Given this list of marker genes POLR2B, NELFE, TAF8, SUPT6H, POLR2G, GTF2H2, EAF1, TAF2, SKIC8, ELOA, GTF2H1, CCNT1, ERCC2, GTF2A1, SUPT4H1, NCBP2, EAF2, GTF2F1, CDK9, TAF9B, GTF2H4, CTR9, TAF4, TAF4B, NELFCD, CCNT2, GTF2B, MLLT3, SSRP1, PAF1, POLR2I, CCNK, GTF2A2, GTF2H3, ELOC, TAF12, NELFB, TAF1L, POLR2J, CDC73, GTF2E1, GTF2H5, POLR2E, IWS1, NCBP1, AFF4, CDK7, SUPT5H, POLR2H, TAF5, SUPT16H, CCNH (cyclin H), ERCC3, POLR2C, CTDP1, POLR2L, POLR2A, TAF1 (TATA-box binding protein associated factor 1), POLR2F (NCBI Gene Id 5435), TBP, TAF9, MNAT1, LEO1, RTF1, GTF2F2, ELOB, MLLT1, TAF3, TAF11, TAF6, ELOA2, GTF2E2, TCEA1, POLR2D, TAF7, NELFA, TAF7L, POLR2K, TAF13, TAF10, ELL, TAF15, here is a description of the gene set: part of: RNA Polymerase II Transcription Reactome Pathway: RNA Polymerase II Pre-transcription Events studied in species Homo sapiens For initiation, Pol II assembles with the general transcription factors TFIIB, TFIID, TFIIE, TFIIF and TFIIH, which are collectively known as the general transcription factors, at promoter DNA to form the pre-initiation complex (PIC). Until the nascent transcript is about 15 nucleotides long, the early transcribing complex is functionally unstable. In the beginning, short RNAs are frequently released and Pol II has to restart transcription (abortive cycling). There is a decline in the level of abortive transcription when the RNA reaches a length of about four nucleotides, and this transition is termed escape commitment